Given this list of marker genes Synj1 (synaptojanin 1), Inpp5b, Ocrl, Inpp4a, Inpp4b, Impa2, Miox, Inpp1, Inpp5j (NCBI Gene Id 170835), Inpp5a, Impa1, Isyna1, here is a description of the gene set: Synthesis of IP2, IP, and Ins in the cytosol Mouse Gene Set: REACTOME_SYNTHESIS_OF_IP2_IP_AND_INS_IN_THE_CYTOSOL species: Mus musculus